The following is a description of a gene set: studied in species Homo sapiens Focal myoclonic seizure Human Gene Set: HP_FOCAL_MYOCLONIC_SEIZURE A type of focal motor seizure characterized by sudden, brief (<100 ms) involuntary single or multiple contraction(s) of muscles(s) or muscle groups of variable topography (axial, proximal limb, distal). Myoclonus is less regularly repetitive and less sustained than is clonus., and this is the list of marker genes: CAMTA1, SDHA, SDHB, GRIN2A, POLG, CACNA1D, PYCR2, PIGA, SATB1, EXTL3, KCTD7, GLUL, SDHD, PLPBP, HACE1, AP3D1, SDHAF1, POU4F1, ALDH7A1